Given this list of marker genes MTOR, NRAS, FLT3LG, PIK3CA, SOS1, FLT3, AKT1, KRAS, PIK3CB, AKT3, SOS2, HRAS, AKT2, PIK3CD, GRB2, here is a description of the gene set: Human Gene Set: KEGG_MEDICUS_REFERENCE_FLT3LG_FLT3_RAS_PI3K_SIGNALING_PATHWAY species: Homo sapiens Pathway Definition from KEGG: FLT3LG -> FLT3 -> GRB2 -> SOS -> RAS -> PI3K -> PIP3 -> AKT -> MTOR FLT3LG-FLT3-RAS-PI3K signaling pathway. Pathway ID: N00218. Pathway type: Reference. Pathway class: nt06262 Pancreatic cancer.